Given this list of marker genes Hmgcl, Oxct1, Bdh1, Hmgcs2, Acat1, here is a description of the gene set: Mouse Gene Set: WP_SYNTHESIS_AND_DEGRADATION_OF_KETONE_BODIES Synthesis and degradation of ketone bodies species: Mus musculus